Given this list of marker genes Rabl2, Rp1l1 (NCBI Gene Id 613256), Dscam, Pdgfb, Six3os1, Mfsd2a, Ift56, Sox8, Grk1, Ntrk2, Fam151b, Tug1, Cdhr1, Agtpbp1, Ush1c, Gabrr2, Ift20 (intraflagellar transport 20), Vax2os, Th, Mir124a-2, Shh, Nphp4, Pcare, Olfm3, Mir183, Nphp1, Cntf, Thrb, Ndp, Otx2, Gngt1, Pax6, Rdh13, Cfh, Rpgrip1l (NCBI Gene Id 73313), Dlx1, Mir124a-1, Dzank1, Dlx2, Samd11, Dio3, Ppp2r3a, Cep290, Fscn2, Mir182, Cngb1, Tulp1, Tmem67, Bhlhe23, Prkci (protein kinase C, iota), Arl3, Crb1, Gnat1, Cfap418, Trpm1, Ihh, Stat3 (NCBI Gene Id 68733), Epg5, Ttc8, Alms1, Poc5, Ahi1, Rom1, Elp6, Rpgrip1, Cabp4, Samd7, Rp1 (retinitis pigmentosa 1 (human)), Vegfa, Ptn, Prom1, Sox9, Nrl, Crb2, Pde6c, Sdk2, Bbs4, Bbs1, Ift140, Notch1, Slc4a7, Mir96, Prdm1, Thy1, Rpgr, Bbs10, Mfrp, Cnga3, Rorb, Prph2, Miat (myocardial infarction associated transcript (non-protein coding)), Casz1, Nr2e3, Hcn1 (hyperpolarization activated cyclic nucleotide gated potassium channel 1), Gnat2, Naglu (NCBI Gene Id 27419), here is a description of the gene set: The specialization of organization of a photoreceptor, a cell that responds to incident electromagnetic radiation, particularly visible light. An example of this process is found in Drosophila melanogaster. Mouse Gene Set: GOBP_PHOTORECEPTOR_CELL_DIFFERENTIATION studied in species Mus musculus